The following is a description of a gene set: BACKGROUND: Deregulation of the Wnt/ beta-catenin signal transduction pathway has been implicated in the pathogenesis of tumours in the mammary gland, colon and other tissues. Mutations in components of this pathway result in beta-catenin stabilization and accumulation, and the aberrant modulation of beta-catenin/TCF target genes. Such alterations in the cellular transcriptional profile are believed to underlie the pathogenesis of these cancers. We have sought to identify novel target genes of this pathway in mouse mammary epithelial cells. METHODS: Gene expression microarray analysis of mouse mammary epithelial cells inducibly expressing a constitutively active mutant of beta-catenin was used to identify target genes of this pathway. RESULTS: The differential expression in response to DeltaNbeta-catenin for five putative target genes, Autotaxin, Extracellular Matrix Protein 1 (Ecm1), CD14, Hypoxia-inducible gene 2 (Hig2) and Receptor Activity Modifying Protein 3 (RAMP3), was independently validated by northern blotting. Each of these genes encodes either a receptor or a secreted protein, modulation of which may underlie the interactions between Wnt/beta-catenin tumour cells and between the tumour and its microenvironment. One of these genes, Hig2, previously shown to be induced by both hypoxia and glucose deprivation in human cervical carcinoma cells, was strongly repressed upon DeltaNbeta-catenin induction. The predicted N-terminus of Hig2 contains a putative signal peptide suggesting it might be secreted. Consistent with this, a Hig2-EGFP fusion protein was able to enter the secretory pathway and was detected in conditioned medium. Mutation of critical residues in the putative signal sequence abolished its secretion. The expression of human HIG2 was examined in a panel of human tumours and was found to be significantly downregulated in kidney tumours compared to normal adjacent tissue. CONCLUSIONS: HIG2 represents a novel non-cell autonomous target of the Wnt pathway which is potentially involved in human cancer. Human Gene Set: KENNY_CTNNB1_TARGETS_UP from publication Kenny PA, Enver T, Ashworth A (PMID 15642117) Genes up-regulated in HC11 cells (mammary epithelium) by expression of constantly active CTNNB1. studied in species Homo sapiens, and this is the list of marker genes: UPP1, TACC3, SEPHS2, SORBS1, HILPDA, SRSF7, ECT2, CCNB1, CTSC, ABI1 (abl interactor 1), ETAA1, TMEM94, TK1, NABP1, TNFAIP2, KRT7, CAPN3, PTPN22, GNA11 (G protein subunit alpha 11), HAT1, CD14 (NCBI Gene Id 929), SYNE1, S100A8, GAN, EBNA1BP2, MMP2, CCN1, RAMP3, SERPIND1, ARFGEF2, ARCN1, NCOR1, RBM26, TFDP1, CCR5, CASKIN2, CSE1L (NCBI Gene Id 1434), HMGB2, PKN1, RPA2, BTRC, PLK4, IGFBP5, LOXL2, TM4SF1, BAD, EXOSC2, SPP1, SQOR, CELF2